The following is a description of a gene set: species: Mus musculus electronically inferred by orthology from the curated human pathway part of: Cell junction organization Reactome Pathway: Cell-cell junction organization This event has been computationally inferred from an event that has been demonstrated in another species.<p>The inference is based on the homology mapping from PANTHER. Briefly, reactions for which all involved PhysicalEntities (in input, output and catalyst) have a mapped orthologue/paralogue (for complexes at least 75% of components must have a mapping) are inferred to the other species., and this is the list of marker genes: Actc1, Psma3, Cbll1, Pomt2, H2ac22, Psma5, H2bc27, H3c7, H2bc9, Ost4, Psma2, Cdh5, Psmd13, Tyk2, Rbbp7, H2ac12, H2bc22, H4c2 (NCBI Gene Id 326620), Csnk2b, Psma4, Psmd7, Cdh1, H2ac24, H2bc7, H2bc11, Ddost, Pard6g, Psmb4, H3c15, H2az2, H2ac8, Smarca4, Psmb6, H2ac19, Banp, H4c17, H4c9, H2ac20, H2ac1, Ctnnb1 (catenin beta 1), H3c10, Jup, Pomt1, Rps27a (ribosomal protein S27A), Spcs1, Cdc42, Nfkb1, Rbbp4, H4c12, H4c14, H3c4, H4c1, Stt3a, H4c6, H3c2, Psma1, Prkcsh, Sec11c, Fyn, Angptl4, Psmd6, Rela (NCBI Gene Id 19697), Psmb7, H2ac4, H2bc8, Psmc2, H3c13, H2ac13, Psma7, H3f3a (H3.3 histone A), Ezh2, Nectin2, H4c8, Psmc3, Ganab (NCBI Gene Id 14376), Mtbp, Cdh12, H4c18, H3c8, Ilf3, Cdh6, Cdh18, Psma6, Ubb, Psmc6, H2ac10, Dad1, H2bc3, Kdm1a, Adam19, H2ac15, Psmc1, Spcs3, H3c1, H3c6, Zmym2, Cadm3, Il6, Cdh2, Pcsk7, Psmd1, Psmd12, Acta1, Dnttip1, Psmc5, Actg2, Sdk1, Cdh15, Psmb5, H4c3, Dnm2, Ang, Ctss, Cdh7, Il6ra, H2ac11, H2bc13 (NCBI Gene Id 319185), H4c11 (NCBI Gene Id 319159), H2ac7, Spcs2, Twist1, Pip5k1c, H3c3 (H3 clustered histone 3), H3c11, Rack1, Nectin4 (NCBI Gene Id 71740), Psmc4, Cdh3, H4c4, H2ac23, Tmem258, H2bc12, H2bc1, Cdh8, H2ac6, H2bc15, H2ax, Pard3